The following is a description of a gene set: Pro-survival signaling of neuroprotectin D1 species: Homo sapiens Human Gene Set: WP_PROSURVIVAL_SIGNALING_OF_NEUROPROTECTIN_D1, and this is the list of marker genes: PPP2CB, BIRC3, RIPK3, CASP7, TNF, TNFRSF1A, CASP9 (NCBI Gene Id 842), TRAF2, BAX, TRADD, CYCS, CASP8, FADD, RIPK1, CASP3